Given this list of marker genes Cycs, Fbl, Ranbp1, Tuba1b, Mrto4, Fkbp1a, Ppp1r14b (protein phosphatase 1, regulatory inhibitor subunit 14B), Nars1 (asparaginyl-tRNA synthetase 1), Slc25a5, Samm50, Fam162a, Hspa8, Commd1, Pgk1, Ube2s, Ddx39a, Tmem37, Prdx1 (peroxiredoxin 1), Atp5mc1, Eif2s1, Fxyd5, Ubl4a, Gzmb, Ddx21, Serpinb9, Proser1, Cfl1, Lgals1, Prf1, Actg1, Anp32b, Stip1 (NCBI Gene Id 51814), Nop58, Dctpp1, Npm3, Rpn1, Prmt1 (NCBI Gene Id 80681), Mrpl52 (mitochondrial ribosomal protein L52), Tcp1, Srm, Psmb10, Arpc1b, Bop1, Snrpd1, Pes1, Metrnl, Ncr1, Srsf2, Ndufb6, Ptprcap, Uqcc2, Ap2m1, Ran, Hspd1, Mrpl19, Klrb1c, Timm50, Phb1, Dda1, Tuba1c, Srsf7, Rbx1, U2af1, Eif4g1, Nhp2, Tubb4b, Sh2d3c, Timm8a1, Bsg, Hsp90ab1, Cotl1, Hspa5, Cox5a, Znhit6, Emc6, Eif4a1, Septin11, Prelid3b, Atp5pf, Spcs2, Psma2, Cyba, Pdia6, Pfn1, Pa2g4, Ppa1, Calr, Dkc1, Ptp4a3, Nkg7, Psmb8, Ncl, Atp5mf, Erh, Gzma, Agpat3, Il2rb, Fcho1, Lat2, Nme1 (NME/NM23 nucleoside diphosphate kinase 1), Hsd11b1, Vasp, Mir142hg, C1qbp, Eif5a, Coro1a, Cdk2ap1, Isyna1, Txndc9, H13, Irf8, Gtpbp4, Calm1, here is a description of the gene set: species: Mus musculus from publication Cui A, Huang T, Li S, Ma A, Pérez JL, Sander C, Keskin DB, Wu CJ, Fraenkel E, Hacohen N (PMID 38057668) Mouse Gene Set: CUI_NK_CELL_IL7_RESPONSE_UP Genes positively differentially expressed in cell type: NK cell upon treatment with cytokine: IL-7 in mouse lymph nodes in vivo. Cytokines mediate cell-cell communication in the immune system and represent important therapeutic targets. A myriad of studies have highlighted their central role in immune function, yet we lack a global view of the cellular responses of each immune cell type to each cytokine. To address this gap, the authors created the Immune Dictionary, a compendium of single-cell transcriptomic profiles of more than 17 immune cell types in response to each of 86 cytokines (>1,400 cytokine-cell type combinations) in mouse lymph nodes in vivo. A cytokine-centric view of the dictionary revealed that most cytokines induce highly cell-type-specific responses. For example, the inflammatory cytokine interleukin-1β induces distinct gene programmes in almost every cell type. A cell-type-centric view of the dictionary identified more than 66 cytokine-driven cellular polarization states across immune cell types, including previously uncharacterized states such as an interleukin-18-induced polyfunctional natural killer cell state.